The following is a description of a gene set: Human Gene Set: GOBP_NEPHRIC_DUCT_FORMATION species: Homo sapiens The developmental process pertaining to the initial formation of a nephric duct. A nephric duct is a tube that drains a primitive kidney., and this is the list of marker genes: GATA3, BMP4, PAX2, WNT9B, HNF1B